Given this list of marker genes NXPH4, NBPF1, LBH, GRB10, NBPF9, TENM1, DENND10, CYP4A11, ARK2N, RPF2, PAK2, HAND1, KDM2A, ADAM22, PCSK7 (proprotein convertase subtilisin/kexin type 7), FBXO45 (NCBI Gene Id 414772), L3MBTL2, FBF1, NAA60, BRD4, SH3BP2, SCN4B, SV2B, CDK16, CC2D1B, NOTCH2, SLC39A10, ITPK1, MAP3K9, PIAS3, MEIKIN, KY, TFDP1, PRX, PLAAT5, CREB5, GCC1 (GRIP and coiled-coil domain containing 1), SKI, CS, MBD3, SLC43A2 (NCBI Gene Id 124935), ABR (ABR activator of RhoGEF and GTPase), DESI1, UTRN, SMLR1, ATXN7L3B, DOCK5, PPP1R11 (NCBI Gene Id 9160), EGR1, PHTF2, TRIM26, ST7L, SMIM24, CNTN2, NBPF12, COTL1, KIF3C, NPR3, AVIL, MAP2, RANBP10, ZC2HC1C, ARMH3, PITPNM2, IQCG, TMCC2, XRCC6, PRM1 (protamine 1), CYP11B1, SYT1, ZSCAN2, FBXL20, WASF2, DOLPP1, SERPINH1, DNALI1, SSR1, MPIG6B (megakaryocyte and platelet inhibitory receptor G6b), BLMH, JARID2, F8, KCND3, SGPP1, WWP2, CAPN2, OTUD6B, MARCHF6, GABRB3, CMTM4, ZNF608, CTTNBP2NL, ERGIC2, PNKD, WASL (NCBI Gene Id 8976), AKAP13, SLC8A2, STUM, RIMS4, CYP7A1, STRN, STAMBP, FPGS, GPR26, NBPF15, FAM83B, SON, HIGD1A, ITGB3BP, CREB1, CHMP7, SLC26A7, ACSBG2, GRIK3, RNF123, AREL1 (apoptosis resistant E3 ubiquitin protein ligase 1), VPS36, VAMP2, RETREG2, RNF44, CCNT2, NBPF3, TSPAN2, PABPC4L, TBC1D10A, DIS3L2, CYP8B1, GJB1, MAPKAPK3, CHL1, KIAA0513, SMARCAD1, MYBBP1A, MINDY2, ASB6, NAV2, PCDH1, NEXMIF, SH3GLB2, OLFM2, GPR63, TEX2, MYPOP, RAB11B, RIT2, GARRE1, EIF1AY, POU4F1 (NCBI Gene Id 730659), COX7A2L, ZNF526, MYADM, FGFRL1, ESR1, TMEM9B, WDFY3, RAB11FIP4, TRAF3, USH2A, CACNA1A, DOC2A, PCDHB10, AMER1, TRPC4AP, SLAIN1, ZNF250, NAV1, KRT73, KL, CACNA1B, NBPF8, NFIL3, PRKAR2A, CRLF3, BMF, N4BP1, UNC5CL, SPTSSB, PARN, TLR9, ZMAT3 (NCBI Gene Id 64393), SCUBE3, U2SURP, SSBP3, TBC1D2B, ATP2B3, CASKIN2, TBC1D13, here is a description of the gene set: Genes predicted to be targets of miRBase v22 microRNA hsa-miR-4514 in miRDB v6.0 with MirTarget v4 prediction scores > 80 (high confidence targets). Human Gene Set: MIR4514 species: Homo sapiens from publication Chen Y, Wang X (PMID 31504780)